Given this list of marker genes CACUL1, PLIN5, RAPGEF3, ITGA6, PIK3R5 (phosphoinositide-3-kinase regulatory subunit 5), CALCA, TAB2, UNC119, DOK7, NEDD9, TRAF6, ARRDC3, TENM1, PDGFRB, ARHGAP11A, UBE2C, BCR, LIMS1, LCP2, COX17, INS, ECT2, TANK, MMD, CRIPTO, PIH1D1, RALGAPA1, LILRA5, FGFR4, PSMD10, RGS7, TOM1L1, CARD14, DOCK9, TBC1D2, MTMR9, TIAM1, HLA-DRB1, MAP3K4, RALGAPB, AGAP2, POLG2, SCRIB, EVI5L, RALBP1, MAPK8, PIP5K1A, XRCC5, MTSS2, IGF1, PLSCR1, SEMG1, DIRAS1 (DIRAS family GTPase 1), LMO4, MAP3K5, DOCK8, STX4, FLT3, BTRC (beta-transducin repeat containing E3 ubiquitin protein ligase), FZR1, SEMA4D, ADCY8, CDKN1A, CCDC88A, CDH3, DRD5, SYDE1, CEMIP, NRG1, TBC1D7, RAPGEF2, ACR, MAPK3, FGFR2, GBA3, DBI, TGM2, DSCC1, ESR1, RHOC (NCBI Gene Id 389), VSIR, FLT1, PIK3R6, MBP, MMD2, LEP, SSBP1, TPD52L1, RALGAPA2, TMIGD3, CARD10, ADIPOQ, DDR2, ARHGEF16, P2RY11, RFC2, CCDC125, ANGPT1, EVI5, ETAA1, GCH1, PILRB, RAB3GAP1, PRTN3, ELANE, RHOG, ABI1, AVPR2, CHI3L1, SRCIN1, CAB39, MID1IP1, RAP1GAP, MAGEC2, PDGFB, TPX2, RAP1A, SPDYA, HMGA2, IRGM, ADAM17, CREB3 (cAMP responsive element binding protein 3), ALS2, SEMG2, DVL3, PSAP, PTK2, TNFRSF10B, RASGRP1, ZNF622, NET1, PTK2B, PTPRC, SGSM3, MAP2K2, PIM1, WRN, PABPN1, TLR3, GPRC5B, RHOA, LTF, ARHGAP11B, DIRAS2, PTPN1, USP6NL, MAP2K1, RGS1, TBC1D20 (TBC1 domain family member 20), ORAI1, RALB, RIPK3, NEK10, MAP3K7, FGFR3, DSTYK, ABR, NPR3, JAK2, SYAP1, CHTF18, CAP1, PDCD10 (programmed cell death 10), ARHGEF5, FGF18, STRADB, PRKCD, SNX9, EDN1, ARHGAP42, PLXNB1, PLA2G5, AZIN2, MMUT, DIPK2A, CENPE, SYDE2, UBE2S, RGS10, FXN, FBN1, PCNA, MAP2K3, NF1, DOCK11, SASH1, F2RL1, SIRT1, GAS6, AGRN, CHTF8, FGFR1, FGF23, RFC5, EDN2, EDNRA, MAPK14, FGF2, ADCYAP1, NTRK1, GNB5, LAT, TRAF4, MAGEA2, MRNIP, TLR6, CORO1C, GUCA1A, TIGAR, RCN3, STRADA, GNAS, ITGB1BP1 (integrin subunit beta 1 binding protein 1), HNRNPU, SNX13, PHACTR4, STOX1, SRC, PRSS22, PIK3CG, CR1, WNT5A, SKP1, RTN4R, GPLD1, TBC1D30 (TBC1 domain family member 30), ERBB2, CD74, S100A12, RFK (riboflavin kinase), RFC3, CHTOP, SIPA1L1, CAMK1, RAB11FIP2, DOCK10, APC2, EZH2, ATPSCKMT, ERN1, TSC1, MT3, DRD4, DYNAP, USP17L2, RACK1, RASGRP2 (NCBI Gene Id 10235), EREG, MST1R (NCBI Gene Id 5755), PRLR, ADORA2B, CDC20, RPS3, CRHR1, SNX18, IFNG, TRAF2, RGS8, RSU1, COPS8, TAOK3, XRCC4, FGF1, RFC4, TCIM, MAP4K2, CSF1R, ADORA3, CDC14B, SERPINB3, CLSPN, SNCA, SH3BP1, PPIA, KIF14, PLAAT4, HSPA1A, RAPGEF1, PRELID1, MAGEA2B, TNFSF15, PNLIP, RGP1, RGS16, SGSM2, VCP, BMP2, BCAS3, SIRT3, MAP3K10, ZC3H15, B3GAT3, EPHA2, ODAM, ARHGEF7, CACNA1D, RANGAP1, NDEL1, MAP3K11, GRN, PSENEN, JTB, BCAR3, RIC1, ARAP1, CASS4 (Cas scaffold protein family member 4), PIBF1, STIM1, CIMAP3, ZNF16, TNFRSF10A, CCNY, CIB1, S100A10, CACNA1C, GUCA1ANB-GUCA1A, ARRDC4, NHEJ1, RAPGEF6, THY1, RPS2, LARS1, CHP2, EEF1A2, STK11, ITGB1, PLK1, CD4, CAP2 (NCBI Gene Id 10486), BMI1, TMSB4X (thymosin beta 4 X-linked), ABL1, GIPR, ZFP91, XRCC6, RASSF2, ASAP3, AKT1, RGS6, SRGAP2, GLP1R, SETMAR, TNF, here is a description of the gene set: Human Gene Set: GOBP_POSITIVE_REGULATION_OF_CATALYTIC_ACTIVITY species: Homo sapiens Any process that activates or increases the activity of an enzyme.